Given this list of marker genes CLRN1, ADCY6, CLRN2, GRXCR2, WHRN, DOCK4, CEACAM16, DIAPH3, RDX, PJVK, PTPRQ, SLC4A7, TRIOBP, PKHD1L1, USH2A, MINAR2, GRXCR1, MYO1C, TMC2, IDO1 (NCBI Gene Id 3620), RAC1, TPRN, TWF2, ADGRV1, PCDH15, HOMER2, CDH23, TMC1, BBS2, CLIC5, MORN4, MKKS, EPS8L2, MYO15A, PIEZO1, CALB1, FSCN2, ATP8B1, STRC, MYO3B, DCDC2, VEZT, STRCP1, EPS8, USH1C, TRPA1, CDC14A, RSPH9, MPP1, ESPN, IFT20, PIEZO2, LOXHD1, MYO3A, CALB2, TSPEAR, PAFAH1B1 (platelet activating factor acetylhydrolase 1b regulatory subunit 1), NHERF1, KPTN, CIB2, ELMOD3, ANKRD24, STX4 (syntaxin 4), MYO7A, RIPOR2, PLS1, RHOC, FCHSD2 (FCH and double SH3 domains 2), ESPNL, KNCN, LHFPL5, PDZD7, here is a description of the gene set: species: Homo sapiens A bundle of cross-linked stereocilia, arranged around a kinocilium on the apical surface of a sensory hair cell (e.g. a neuromast, auditory or vestibular hair cell). Stereocilium bundles act as mechanosensory organelles by responding to fluid motion or fluid pressure changes. Human Gene Set: GOCC_STEREOCILIUM_BUNDLE